The following is a description of a gene set: Human Gene Set: GSE17721_LPS_VS_POLYIC_2H_BMDC_UP mouse primary BMDCs were stimulated with tlr ligands and gene expression changes were profiled on Affymetrix arrays Genes up-regulated in comparison of dendritic cells (DC) stimulated with LPS (TLR4 agonist) at 2 h versus DC cells stimulated with poly(I:C) (TLR3 agonist) at 2 h. from publication Amit I, Garber M, Chevrier N, Leite AP, Donner Y, Eisenhaure T, Guttman M, Grenier JK, Li W, Zuk O, Schubert LA, Birditt B, Shay T, Goren A, Zhang X, Smith Z, Deering R, McDonald RC, Cabili M, Bernstein BE, Rinn JL, Meissner A, Root DE, Hacohen N, Regev A (PMID 19729616) species: Homo sapiens, and this is the list of marker genes: STIP1, ZAN, EGLN3, LY96, CENPV, FAM133B, TLL2, EFS (NCBI Gene Id 10278), DENND2D, MAD2L1, SRP54, PLAT, SLC12A4, NFKBIB, RAP1B, RNF19B, IRF1, EGR1, COL11A1, TAX1BP1, P2RY14, ATAD1, IL12A (NCBI Gene Id 3592), LMO4, ANXA7, PIGT, TNFSF8, FPR1, STK40, SNX18, STAMBPL1, HCCS, DSCAML1, MSH5, SASH1, KLF6 (KLF transcription factor 6), CDC42EP1, CLOCK, SLAIN2, STAG1, CACHD1, SCUBE1, RGL1, CR2, MFSD14B, CACNA1D, ACSL1, CPEB2, CA3, FABP4, SPIRE2, BRI3, HAGH, IL36G, PITX1, IDI1, MT2A, EPHA2 (EPH receptor A2), RELA, ADHFE1, KLF9, CABP2, SLC7A11, CAPN9, SUCO, AMPD3, CYP39A1, SLC27A5, CD200, AANAT, MET, ARF6 (NCBI Gene Id 63379), TM7SF2, MCOLN2, UBE2H, TPP2, TLR6, UBE2F, UFM1, MDFIC, PIM3, RNF11, ITGA4, GAS7, PLG, NFKBIA, PON3, RAB38, NCK1, P4HA2, WNK1, TLR1, DUSP1 (NCBI Gene Id 1843), ADAM12, TMED5, RBM7, ANKRD1 (ankyrin repeat domain 1), PLA2G2E, APAF1, NUP62, CST9L, EPM2A, ST3GAL1, CKS2, TRAF1, WDR48, PHLDA1, CLN3, LAG3, TMEM39A, CYTH2, GRID2, PAX7, CD38, NFKB1, DNAJB6, IL1RN, HMGB2, RGS2, IL36A, NFKB2, MTF1, LY75, RCN2, TFEC, EIF2B2, TYMS, PSPC1, FDFT1, SAA1, DLST, EMD, DEXI, NANOG, TNFSF11, MTDH, VCAM1, KCNIP4, PALLD, PLCL2, CSF3, BCL10, DENR, GPR155, EDA (NCBI Gene Id 90878), MARCHF5, CALCRL, ZRSR2, ALDH3A1, FMR1 (fragile X messenger ribonucleoprotein 1), PDPN, SERPINE1, IFITM2, BRD2, VGLL1, S100A1, KLB, TOB1, RTL8C, SMAD1, PLPP3, ZNF598, NR3C1, CD86, SLC26A1, SLC16A4, ANG, LPAR1, GPR85, ACTL7A, CDV3, MMD, RILPL2, CHD1, AKR1D1, SPTAN1, SLC25A17, IKZF2, LTV1, RLF, PRKCH (protein kinase C eta), SNTG2, KBTBD2, RRS1, SLC30A7, CCL13, GMEB1, TUBB2A, FKBP9, NEAT1, COQ3, POLR3D, EPM2AIP1, SLC31A1, KDM5C, CLDN19, MDM2 (NCBI Gene Id 84825), NUDT9, FCGR2B, LAMA2